Given this list of marker genes Kir3dl2, Antxr1, Kir3dl1, Agap1, Cdkl3, Sprr1b, Otx1, here is a description of the gene set: from publication Chen Y, Wang X (PMID 31504780) Genes predicted to be targets of miRBase v22 microRNA mmu_miR_425_3p in miRDB v6.0 with MirTarget v4 prediction scores > 80 (high confidence targets). Mouse Gene Set: MIR_425_3P species: Mus musculus